The following is a description of a gene set: The birth of a baby of less than 37 weeks of gestational age. Human Gene Set: HP_PREMATURE_BIRTH species: Homo sapiens Premature birth, and this is the list of marker genes: YRDC, PTCH1, CAPNS1 (NCBI Gene Id 826), PEX19, DBR1, MYT1L, SMC1A, CNOT1, PTH1R, FIG4, LAGE3, PEX13 (NCBI Gene Id 5194), DCLRE1B, STAT2, SKIC2, RPL10, RAD21, GLI2, PAX2, BRD4, ALB, FLVCR2, CRIPTO, TRAF7, ADAMTS2, SFTPC, HYLS1, DHCR7, COL3A1, HOXD13, PNPO, MAP2K2, GALK1 (NCBI Gene Id 2584), BCR, PEX1, CRB2, AIMP1, COL5A1, DHPS, MAPK1, CLCNKB, SUFU, SLC12A1, NDUFB11, LMOD3, WDR73, CCDC47, MTM1, NUP133, ZFX, STRADA, BSND (barttin CLCNK type accessory subunit beta), NDUFB3, FDXR, MEG3, MYH7 (NCBI Gene Id 8090), DLL4, LYN (LYN proto-oncogene, Src family tyrosine kinase), FBN1, CLCNKA (chloride voltage-gated channel Ka), PBX1, TGIF1, MUSK, ZMPSTE24, PEX5, ABCA12, SIX3, NUP107, SMPD4, SLC17A5, RALGAPA1, RNU4ATAC, COQ4, SATB1, CNTN1, RBPJ, DISP1, FLNB, MED12 (mediator complex subunit 12), PEX16, FLI1, QRSL1, HDAC8, GATC, NOTCH1, SF3B4, KIF7 (NCBI Gene Id 46), ABCB4, MAGED2, SFTPB, NEB, KLHL41, SLC16A2, WDR4, ABCB11, ASCC1, RTL1, COL1A1, GON7, EOGT, IGHMBP2, TAF6, ESCO2, FBXL4, LTBP3, NODAL, COL5A2, SLC26A3, MAP2K1, ALG8, GLB1, ACTA1, FZD4, KCNJ1, OSGEP, PCDH12, FGF8, TP53RK, GBA1, NIPBL (NIPBL cohesin loading factor), PEX6, PEX12, ALG12, SARS2, HBB, PEX26, BRAF, COL11A1, ATP8B1, FCSK (fucose kinase, NCBI Gene Id 197258), KLHL40, INTS11, ARHGAP31, FGFR1, WDR62, SMC3, PEX10, ZNF699, SERPINE1, SLC27A4, YARS1, DLL1, TRIP4, TPRKB, GATB, CYP11A1, COPB2, PEX11B (peroxisomal biogenesis factor 11 beta), CDON, TMEM70, DLK1, DOCK6, NR1H4, KRAS, SHH, PEX3, SMARCAL1, EBF3, CLCN7, NDP, RPS19, THOC2, LRP5, ABCA3, WARS2 (NCBI Gene Id 10352), LMNA, DMPK, B4GALT1, HRAS, NLRP3, TPM3, ASNS, COL1A2, ZIC2, GAS1, PEX14, FOXH1, TSHR, VARS1, PEX2, CRKL